Given this list of marker genes IL36B, IL6, TNFSF18, CASP3, CCL11, SPRED2, SDCBP, CCL4L2, CCL19, GRB2, CFLAR, TLR5, CXCL11, CCL2, CSF3, TGFBR3L, IFNA4, IFNA17, MADD, XCL2, FASLG, TRAF4, C5, DAB2IP, IL23R, IL1A, IFNW1, DEFB114, CXCL2, IL6ST, ITGB3, CSHL1, IFNA2, IL12RB1, NTF3, STAT3, CSH2, AMH, BABAM2, PIK3R1, ADAM17, OSMR, IFNA14, IFNA7, IFNL1, VEGFA, TNFSF4, IL36RN, IL12B, SOCS1, RHEX, JAK3, CCL3L3, TRAF5, TGFB2, TNFSF12, IFNA21, IFNE, MIF, IFNA10, IL3, IFNA5, SPRED1, CXCL6, RASL11B, IL37, IL22, PYCARD, CXCL13, OSM, TRAF3, ADAM8, FRS2, PF4V1, MYD88, IL12A, DEFB110, IFNB1, NTRK1, EDA, DEFB106A, DNAJA3, BDNF, TMBIM1, CXCL5, IL34, DEFB106B, LTB, SNX6, TNFSF13B, IFNK (NCBI Gene Id 95265), USP15, IFNA8 (NCBI Gene Id 95818), PGF, NOL3, YARS1, CSF1, IL10, KITLG, EPO, DEFB4A, CD40LG, DDT, PPBP, TYK2, CXCL1, GREM1, CCL7, IL21, TGFB1, TRAF6, NGF, IL1F10, IL27 (NCBI Gene Id 246778), MAP3K7, CCDC88A, IL2, SMAD6, IL17F, BEX3, TFF2, IFNA6, LIF, CCL1, CXCL3, CSF2, PXDN, VEGFD, CKLF, CASP8AP2, GPR15LG, CCRL2, CSH1, ITGA5, INHBC, CNIH4, TIMM50, PLCG1, RNF41, IL1B, EFNA5, JAK2, MSMP, CASP8, CADM4, CCL24, CXCL14 (NCBI Gene Id 9547), PDCL3, TNFSF10, TRIM37, TNFSF9, LEFTY2, VEGFC, TRAF1, TNFSF13, IL13, CRLF1, NARS1, ECM1 (extracellular matrix protein 1), IL31, CCL28, IL5, SOCS3, CD300LF, CXCL8, FERMT2, NTF4, TNFSF8, TRAP1, NES, IL36A, CCL23, LRG1, TGFBR2, SMAD7, CCL17, IL11, CCL5, DEFB1, LIFR, TNFSF15, SMAD2, STAT1, RIPK1, CCL4, IL4, DEFB130A, SHC1, SMAD3, VEGFB, CCL22, CCL26, CCL27, CCL13, DEFB103B, DEFB109B, LTA, FKBP1A, CCR2 (C-C motif chemokine receptor 2), TGFB3, IL23A, IL15, CTF1, TGFBR1, SMURF1, LEFTY1, TRAF2, CD70, CX3CR1, PIBF1, IFNA1, IL33, CCL20, JAK1, TNF (tumor necrosis factor), FADD, DEFB133, CISH, TNFSF11, TOLLIP, CCL3, SYK, S100A14, IFNG, IL1RN, PF4, GATA3 (NCBI Gene Id 84828), IL9, IL25, CXCL9, CNTF, PIDD1, BID, IL18, CCL18, CLCF1, CXCL12, CCL16, SH2B3, FEM1B, EBI3, IL7, CDH5, DEFB130B, CCL21, PRL, GH2, IRAK4, CX3CL1, TNFSF14, CCL14, CCL8 (C-C motif chemokine ligand 8), TSLP, XCL1, TGFBRAP1, CXCL16, IL6R (NCBI Gene Id 3570), STAP1, TLR9, DEFB103A (NCBI Gene Id 414325), CREB3, ITCH, CCL15, CXCL10, TRIP6, TGFBR3, SIVA1, GH1, IL36G (NCBI Gene Id 56300), CCL25, ENG, BAMBI, IL20, ERAP1, IFNA16, SOCS2, here is a description of the gene set: Binding to a cytokine receptor. studied in species Homo sapiens Human Gene Set: GOMF_CYTOKINE_RECEPTOR_BINDING